Given this list of marker genes SALL4, TWIST1, MAFB, FGFR3, CHN1, PRRX1, GJB2, POLR1C, POLR1D, ERF, EYA1, FGFR2, TCOF1 (treacle ribosome biogenesis factor 1), OTX2, POLR1B, SIX1, NEUROG1, AKT1, POU3F4, ANKH, GJB6, here is a description of the gene set: An abnormality of the Internal acoustic meatus, i.e., of the canal in the petrous part of the temporal bone through which the cranial nerve VII and cranial nerve VIII traverse. species: Homo sapiens Human Gene Set: HP_ABNORMALITY_OF_THE_INTERNAL_AUDITORY_CANAL Abnormality of the internal auditory canal